Given this list of marker genes Clec7a, Asl, Hsp90ab1, Agxt2, Oprm1, Dnm2, Mtor, Ulbp1, Insr, Tlr4, Icam1, Hsp90aa1, Klf2, Tlr2, Tmem106a, App, Pik3cb, Ptk2b, Agt, Pkd2 (polycystin 2, transient receptor potential cation channel), Mapk9, Itgb2l, Ptx3, Tlr6, Trpv1, Ticam1, Apoe, Akt1, Itgb2, Sod2, Npy, Tnf, Il1b, Crp, Klf4 (Kruppel-like transcription factor 4 (gut)), Nfatc3, Ifng, Clu (NCBI Gene Id 28201), Ass1, Hrh1, Raet1d, Ddah1, Il6, Tlr5, Akt2, Aif1, Jak2, Klrk1, H2-M3, Ptgs2, Cd36, Smad3, Esr1, Smpd3, here is a description of the gene set: species: Mus musculus Mouse Gene Set: GOBP_POSITIVE_REGULATION_OF_NITRIC_OXIDE_METABOLIC_PROCESS Any process that activates or increases the frequency, rate or extent of nitric oxide metabolic process.